The following is a description of a gene set: studied in species Mus musculus Mouse Gene Set: REACTOME_INTERACTION_BETWEEN_L1_AND_ANKYRINS Interaction between L1 and Ankyrins, and this is the list of marker genes: Sptbn5, Sptb, Sptan1, Sptbn2, Spta1, Sptbn1, Actg1, Ank1, Actb, Sptbn4